The following is a description of a gene set: species: Mus musculus Mouse Gene Set: GOBP_NEGATIVE_REGULATION_OF_LIPASE_ACTIVITY Any process that decreases the frequency, rate or extent of lipase activity, the hydrolysis of a lipid or phospholipid., and this is the list of marker genes: Angptl8, Pla2r1, Apoc3, Apoa2, Sort1, Apoc1, Angptl4, Angptl3, Rgs2, Plin5